Given this list of marker genes ACSM2A, NUDT7, ACOT7, HSD17B4, NUDT19, NUDT8, here is a description of the gene set: studied in species Homo sapiens The chemical reactions and pathways involving medium-chain fatty-acyl-CoAs, any derivative of coenzyme A in which the sulfhydryl group is in a thioester linkage with a long-chain fatty-acyl group. A medium-chain fatty acid has an aliphatic tail containing 6 to 12 carbons. Human Gene Set: GOBP_MEDIUM_CHAIN_FATTY_ACYL_COA_METABOLIC_PROCESS